Given this list of marker genes FGF10, TGFBR3, GIPC1, FGF22, FGF1, FGFR1, FGF2, FGF3, here is a description of the gene set: FGFR1b ligand binding and activation studied in species Homo sapiens Human Gene Set: REACTOME_FGFR1B_LIGAND_BINDING_AND_ACTIVATION